Given this list of marker genes MAPK3, DOK6, SHANK3, PIK3CA, MAPK1, RAC1, PXN, CREB1, RHOA, PDLIM7, BCAR1, GAB1, HRAS, GFRA1, IRS2, RET, DOK5, IRS1, GRB10, DOK1, JUN, PTK2, GRB2, SHC1, MAPK8, PRKACA, RAP1A, CRK, GRB7, GDNF, PIK3R1, NCK1, RASA1, FRS2, SRC, DOK4, SOS1, PTPN11, PRKCA, here is a description of the gene set: from publication Schaefer CF, Anthony K, Krupa S, Buchoff J, Day M, Hannay T, Buetow KH (PMID 18832364) Signaling events regulated by Ret tyrosine kinase species: Homo sapiens Human Gene Set: PID_RET_PATHWAY